The following is a description of a gene set: studied in species Mus musculus The mouse aldehyde oxidase AOH2 (aldehyde oxidase homolog 2) is a molybdoflavoenzyme. Harderian glands are the richest source of AOH2, although the protein is detectable also in sebaceous glands, epidermis, and other keratinized epithelia. The levels of AOH2 in the Harderian gland and skin are controlled by genetic background, being maximal in CD1 and C57BL/6 and minimal in DBA/2, CBA, and 129/Sv strains. Testosterone is a negative regulator of AOH2 in Harderian glands. Purified AOH2 oxidizes retinaldehyde into retinoic acid, while it is devoid of pyridoxal-oxidizing activity. Aoh2(-/-) mice, the first aldehyde oxidase knockout animals ever generated, are viable and fertile. The data obtained for this knockout model indicate a significant role of AOH2 in the local synthesis and biodisposition of endogenous retinoids in the Harderian gland and skin. The Harderian gland's transcriptome of knockout mice demonstrates overall downregulation of direct retinoid-dependent genes as well as perturbations in pathways controlling lipid homeostasis and cellular secretion, particularly in sexually immature animals. The skin of knockout mice is characterized by thickening of the epidermis in basal conditions and after UV light exposure. This has correlates in the corresponding transcriptome, which shows enrichment and overall upregulation of genes involved in hypertrophic responses. Genes up-regulated in skin upon knockout of AOX4. Human Gene Set: TERAO_AOX4_TARGETS_SKIN_UP from publication Terao M, Kurosaki M, Barzago MM, Fratelli M, Bagnati R, Bastone A, Giudice C, Scanziani E, Mancuso A, Tiveron C, Garattini E (PMID 18981221), and this is the list of marker genes: TRPC4AP, LRRC46, KRIT1, RAD23B, VPS29, WDR45B, H2AC8, KCNH1, FGD1, NSUN6, TMC4, RPS18, ERBIN, FZD10, H2AC7, MRPL38, EFNB1, ATP7A, SEC63, RTN4, TOMM40, DNAJC5, SFN, POLR3F, ERC1, SMG6 (NCBI Gene Id 80091), BCLAF1, ELOVL7, LPGAT1, PA2G4, METTL1